The following is a description of a gene set: species: Homo sapiens Endoplasmic reticulum mannosyl-oligosaccharide 1,2-alpha-mannosidase (MAN1B1) normally trims single mannose residues from misfolded glycoproteins, targeting them for degradation and thus providing a quality control process for N-glycoyslated proteins. Defects in MAN1B1 can cause mental retardation, autosomal recessive 15 (MRT15; MIM:614202), a disorder resulting in nonsyndromic moderate to severe mental retardation. It is characterised by significantly below average intellectual functioning associated with impaired adaptative behaviour during the developmental period. part of: Diseases associated with N-glycosylation of proteins Reactome Pathway: Defective MAN1B1 causes MRT15, and this is the list of marker genes: MAN1B1 (NCBI Gene Id 51697)